Given this list of marker genes PTN, MDK, SLAMF8, FFAR2, LBP, ALOX5, SLAMF1, NINJ1, here is a description of the gene set: Human Gene Set: GOBP_LEUKOCYTE_CHEMOTAXIS_INVOLVED_IN_INFLAMMATORY_RESPONSE The movement of an immune cell in response to an external stimulus contributing to an inflammatory response. species: Homo sapiens